The following is a description of a gene set: Genes from the pink module which are dn-regulated in HAEC cells (primary aortic endothelium) after exposure to the oxidized 1-palmitoyl-2-arachidonyl-sn-3-glycerophosphorylcholine (oxPAPC). Human Gene Set: GARGALOVIC_RESPONSE_TO_OXIDIZED_PHOSPHOLIPIDS_PINK_DN studied in species Homo sapiens from publication Gargalovic PS, Imura M, Zhang B, Gharavi NM, Clark MJ, Pagnon J, Yang WP, He A, Truong A, Patel S, Nelson SF, Horvath S, Berliner JA, Kirchgessner TG, Lusis AJ (PMID 16912112) Oxidized phospholipids are thought to promote atherogenesis by stimulating endothelial cells (ECs) to produce inflammatory cytokines, such as IL-8. In studies with mouse models, we previously demonstrated that genetic variation in inflammatory responses of endothelial cells to oxidized lipids contributes importantly to atherosclerosis susceptibility. We now show that similar variations occur in cultured aortic ECs derived from multiple heart transplant donors. These variations were stably maintained between passages and, thus, reflect either genetic or epigenetic regulatory differences. Expression array analysis of aortic EC cultures derived from 12 individuals revealed that >genes were regulated by oxidized phospholipids. We have used the observed variations in the sampled population to construct a gene coexpression network comprised of 15 modules of highly connected genes. We show that several identified modules are significantly enriched in genes for known pathways and confirm a module enriched for unfolded protein response (UPR) genes using siRNA and the UPR inducer tunicamycin. On the basis of the constructed network, we predicted that a gene of unknown function (MGC4504) present in the UPR module is a target for UPR transcriptional activator ATF4. Our data also indicate that IL-8 is present in the UPR module and is regulated, in part, by the UPR. We validate these by using siRNA. In conclusion, we show that interindividual variability can be used to group genes into pathways and predict gene-gene regulatory relationships, thus identifying targets potentially involved in susceptibility to common diseases such as atherosclerosis., and this is the list of marker genes: MYCN, NRP2, GBP2, CRACR2B, TMEM140, CEP68, CERT1, GIMAP7, CYP26B1, PLXNA4, THBD, LONRF3 (NCBI Gene Id 79836), EHD3, ZNF704 (NCBI Gene Id 84737), LYN, GIMAP2, DEPP1, HS3ST1 (NCBI Gene Id 9957), LRIG3, TNFSF10, SEMA6D, ARHGAP28 (NCBI Gene Id 79822), GIMAP6, MEF2C, ACKR4 (atypical chemokine receptor 4), ZNF608, LPAR6, ZNF436, BBS10, FILIP1, ZEB2, HECW2-AS1, GIMAP8, PALMD